Given this list of marker genes Krtap2-4, Krtap3-3, Krtap10-27, Krt7, Kazn, Krtap2-22, Gm5414, Krtap10-32, Krtap9-5, Krt15, Krtap4-20, Krt31, Krtap9-21, Krtap29-1, Krtap20-20, Pkp2, Krt86, Krtap16-3, Krt12, Gm5478, Krtap1-5, Krtap20-22, Krt87, Gm4553 (predicted gene 4553), Krt19, Krtap6-1, Krtap12-20, Krtap19-2, Krt9, Krtap4-16 (NCBI Gene Id 435285), Krt14, Krt5, Krt39, Krt75, Krtap10-24, Krtap10-30, Dsg2, Krt83, Ppl, Krt20, Stfa2l1, Krtap10-10, Krtap5-25, Krtap6-5, Cela2a, Krtap10-22, Dsp (desmoplakin), Krtap12-1, Sprr3, Krtap13 (keratin associated protein 13), Krt85, Krt16, Krtap10-33, Klk8, Klk13, Krtap6-6, Klk12 (kallikrein related-peptidase 12), Gm10153 (predicted gene 10153), Krt24, Krtap10-26, Krt18, Krtap5-23, Krtap1-3, Krtap13-22, Krtap10-21, Evpl, Krtap13-21, Spink6, Klk5, Krtap11-1, Krtap31-2, Krtap4-13, Krtap10-28, Krtap4-24, Krt8, Krtap13-1, Krtap5-20, Krtap5-21, Klk14, Krtap4-27, Krt26, Krtap12-22, Krt71, Stfa2, Krtap4-2, Krt2, Krt4, Rptn, Krt27, Krtap31-1, Krt35, Krtap5-26, Krtap16-1, krtap20-23, Krtap9-3, Krtap10-29, Tgm1, Krtap19-5, Gm36368, Krtap4-7, Krtap10-25, Krtap2-20, Krt73, Krt40 (keratin 40), Krtap5-1, Krt80, Krtap13-23, Krt23, Krt33b, Dsg1a, Krt13, Krtap4-8, Pkp4, Krt33a, Krt25, Krtap4-26, Krtap10-34 (NCBI Gene Id 100503388), Dsc1, Krtap3-1, Casp14, Krtap3-2, Krt36, Krtap4-25, Tchh, Lipn, Lipm, Perp (NCBI Gene Id 80493), Krtap4-21, Dsg3, Jup, Lipk, Krtap13-20, Pkp3, Krt6a, Krtap4-22, Pkp1, Krtap9-1, Krtap19-4, Krtap9-20, Krt77 (keratin 77), Krtap20-2, Krtap5-24, Krtap31-3 (NCBI Gene Id 670550), Krtap20-21, Krtap12-21, Krt10, Krt1, Krt74, Krt79, Krtap5-4, Krtap6-7, Krtap10-31, Krt28, Krt78, Krtap10-4, Krtap19-3, Krtap4-1, Krt32, Krtap24-1, Krtap2-21, Krtap4-9, Krtap20-24, Krt17, Krt84, Krt82, Krtap5-22, Krtap4-23, Krt76, Krtap5-5, Krt72, Dsc3, Krtap10-23, Dsc2, Krtap9-22, Krtap4-6, Krtap8-1, Spink5, Krtap6-3, Krt34, Krtap1-4, Dsg4, Krtap5-2, Krt6b, Krtap20-1, Krtap19-1, Cdsn, Krt81, here is a description of the gene set: Mouse Gene Set: REACTOME_KERATINIZATION species: Mus musculus Keratinization